Given this list of marker genes Pxylp1, Mustn1, Ctnnb1, Tcf7l2, Slc2a10, here is a description of the gene set: Any process that activates or increases the frequency, rate or extent of the chemical reactions and pathways resulting in the formation of proteoglycans, any glycoprotein in which the carbohydrate units are glycosaminoglycans. studied in species Mus musculus Mouse Gene Set: GOBP_POSITIVE_REGULATION_OF_PROTEOGLYCAN_BIOSYNTHETIC_PROCESS